Given this list of marker genes LINS1, COMMD5, IL3, WWC2-AS2, FAM13C, TBX5, MKLN1, RGS14, TSPAN13, HOXC6, SPINK6, RYBP, IL17F, NHSL2, HPCAL1, TACC2, LINC00649, AP5B1, CYTIP, IL17A, RHOG, ENTPD3, CBL, TRPV2, PTPRS (protein tyrosine phosphatase receptor type S), TNFRSF12A, STON1-GTF2A1L, HSP90B1, RUNX2, HEY1, RBBP6, MTMR4, EYA1, APOBR, CD6, ELAVL2, CFP, FOXN3, C14orf119, MND1, PBK, CPNE1, ADAMTS8, REXO2, EMP1, DOK2, MSMB, AKT2, AGPAT4, ZBTB25, PAX1, GABRA6, PIK3R1, WBP1, PPP1R12C, GPR155, RABGAP1L, SWT1, MSRA, RASSF2, PRRG4, SASH3, LIFR, IL17RE (NCBI Gene Id 132014), JMJD1C, CLDND1, SUPT16H, ACVR2A, RGS1, LTBP1, CNTD1, BMPR1B, NEK6, SPIB, CRY1, TMEM215, TRMT1L, PTPN22, GPBP1L1, TULP4, TCF12 (NCBI Gene Id 6938), ERG, FLI1, ETF1, SLC31A2, LCK, THBS3, MAP1LC3A, ITGB7, CDC37L1, EDC4, GPR50, CCNT2, SIRT1, IFNG, ZBTB8A, MAFG, OTP, SCRN1, MATN1, AGO1, RPP21, CFAP20, MIR17HG, PICALM, STON1, PPARG, FOXP3, SDF2L1, ARHGAP45, TRPM8, KCTD15 (NCBI Gene Id 79047), PPP1R14C, AKAP3, PROK2 (NCBI Gene Id 60675), OLIG3, SGIP1, TAGAP, VASN, RIN1, DAB2IP, MTMR3, ADAM28, NUCB2, GPX1, SCAI, NAPSA, SLC26A7, NIBAN3, LRATD1, BLOC1S1, ATP5F1A, HOXB4, KRT10-AS1, TMEM86A, RNF43, PLXNC1, SREBF2, RGMA, HOXB5 (NCBI Gene Id 3215), NDUFA3, CCL2, SLC12A6, FCER1G, ZIC4, PRR5L, WNK4, MSI2, HOXA9, MTMR11, CFH, CEMIP, SYT9, DGKZ, CHAD, LIF, GPR15, LINC02694, TCF7, OSCAR, KCNJ1, MADD, TMEM151A, TBL1X, ZNF821, PDGFC, SUPT4H1, CXCR3, EIF5A, CCR1, HOXB6, TBC1D10B (NCBI Gene Id 26000), LUC7L, GRHL3, FAM117A, C1QTNF6, HOXB3, MTX1, NAV3, TLN1, CALR, BATF3, PDZD2, PAFAH1B1, SOX5, TP63, ABHD8, KRTAP6-3, IL7R, FDCSP, ATF7IP, ASB7, UBE2R2, BCAR3, HOXD10, CALCOCO1, TSSK2, SRSF4, RTN4RL1, TBPL1, HHIP, ZEB2, TWF1 (NCBI Gene Id 82712), WNT8B, ARHGEF2, CD28, SLC43A2, DMP1, GPR171, DAB2, LINC00314, CD69, ACIN1, ARHGAP30, FGFR1, CITED1, ARHGAP8, HLX, PPP2R3A, ID3, LRMDA, WAS, ASCL4, DKK1, KLHDC9, NSUN4, NUTF2, ZFHX3, SLA2, COA3 (cytochrome c oxidase assembly factor 3), POLG2, SELENOH, POU2F1, PITPNC1, STAU1, SLC36A2, PGF, POF1B, CPA2, DYRK1B, SOST, AMD1, CSF2, SMG7, PCSK5, RPA3, SLC44A4, RUNX1, GTF2A1 (NCBI Gene Id 50857), PDE6H, BCL6, APLNR, BNC2 (NCBI Gene Id 54796), HOXC4, AP1S2, SCNN1A, PHF6, ODAPH, RPP25L, HEMGN, BATF, EVI2A, SCN2B, EDARADD, CCL4, GPD1, REL, CTHRC1, PHF21A, here is a description of the gene set: Genes having at least one occurrence of the highly conserved motif M111 RACCACAR in the regions spanning 4 kb centered on their transcription starting sites. This matches the RUNX1 transcription factor binding site V$AML_Q6 (v7.4 TRANSFAC). from publication Xie X, Lu J, Kulbokas EJ, Golub TR, Mootha V, Lindblad-Toh K, Lander ES, Kellis M (PMID 15735639) Comprehensive identification of all functional elements encoded in the human genome is a fundamental need in biomedical research. Here, we present a comparative analysis of the human, mouse, rat and dog genomes to create a systematic catalogue of common regulatory motifs in promoters and 3' untranslated regions (3' UTRs). The promoter analysis yields 174 candidate motifs, including most previously known transcription-factor binding sites and 105 new motifs. The 3'-UTR analysis yields 106 motifs likely to be involved in post-transcriptional regulation. Nearly one-half are associated with microRNAs (miRNAs), leading to the discovery of many new miRNA genes and their likely target genes. Our results suggest that previous estimates of the number of human miRNA genes were low, and that miRNAs regulate at least 20% of human genes. The overall results provide a systematic view of gene regulation in the human, which will be refined as additional mammalian genomes become available. studied in species Homo sapiens Human Gene Set: RACCACAR_AML_Q6